Given this list of marker genes TMC5, NALF2, TMC1 (NCBI Gene Id 53634), NALF1, TMC7, PIEZO1, TMC2, TMC8, TMC3, KCNK2, TMEM150C, KCNK4, TMEM63A, TMC6, TMEM63B, KCNK10, TMEM87A, PIEZO2, TRPV4, TMC4, here is a description of the gene set: species: Homo sapiens Human Gene Set: GOMF_MECHANOSENSITIVE_MONOATOMIC_ION_CHANNEL_ACTIVITY Enables the transmembrane transfer of an monoatomic ion by a channel that opens in response to a mechanical stress.